The following is a description of a gene set: species: Homo sapiens Human Gene Set: GOBP_AMINE_METABOLIC_PROCESS The chemical reactions and pathways involving any organic compound that is weakly basic in character and contains an amino or a substituted amino group. Amines are called primary, secondary, or tertiary according to whether one, two, or three carbon atoms are attached to the nitrogen atom., and this is the list of marker genes: HDC, NPR1, AOC2, AOC1, DHPS, AGMAT, ACMSD, SATL1, EPAS1, PAOX, DDC, SNCB, SNCAIP, NR4A2, DMGDH, GCH1, HPRT1, NAAA (NCBI Gene Id 27163), SULT1A1, MAOB, KL (NCBI Gene Id 9365), VPS35, DRD1, DBH, DRD4, TH, OAZ2, HAAO, SLC22A3, TACR3, SLC29A4 (solute carrier family 29 member 4), ODC1, MIR21, MOXD1, IL4I1, SULT1A4, HDAC6 (histone deacetylase 6), SULT1B1, HTR1A, SLC44A1, AANAT, SLC6A3, KYNU, RNF180 (NCBI Gene Id 285671), ATP2B4, ALDH7A1, CHRNB2, PNMT, VCAM1, ATP7A, CYP1A1, SULT1A3, GDPD3, GRIN2A, PRG3, MAOA, COMT, NT5DC2 (5'-nucleotidase domain containing 2), PNKD, DRD3 (NCBI Gene Id 2111), RTL4, TDO2, HAND2, GCDH, PRKN, NPY, GATA3, AZIN1, SLC1A1, CHDH, INMT, NAPEPLD, OAZ3, KMO, HNMT, ALDH2, SMOX, AFMID, SAT1, ABAT, ASMT, GPR37, PARK7, SAT2, AOC3, EDNRA (endothelin receptor type A), PDE1B, TRH, AZIN2, IDO2, INSM1, OAZ1, GDPD1, SLITRK1, MOXD2P, DRD2, SULT1C2, TGFB2, SRM, MECP2, AMD1 (NCBI Gene Id 262), IDO1, ITGAM, SNCA, GNAT2 (NCBI Gene Id 92084), PAH, SULT1A2, ITGB2, NADSYN1, DAO, FSHR, GDE1, SMS, HDAC10